The following is a description of a gene set: studied in species Mus musculus from publication Chen Y, Wang X (PMID 31504780) Mouse Gene Set: MIR_6900_3P Genes predicted to be targets of miRBase v22 microRNA mmu_miR_6900_3p in miRDB v6.0 with MirTarget v4 prediction scores > 80 (high confidence targets)., and this is the list of marker genes: Mbnl2, Cers6, Cd226, BC061237, Peg10, Ski, Fmo2, Trim45, Nefl, Akap7, Rims2, Mkks, Nkain2, Vps33a, Cx3cl1, Ap1s2, Rgs9, Smurf1, Kansl1, Mdga1, Lhx5, Zfp365, 1700066M21Rik, Rack1, Fhip1b, Stk32b, D630003M21Rik, Atg10, Rnf115, Thrb, Arhgdib, Virma, Klf11, Acsl6, Brox, Clvs1, Shisa7, Nnat, Cul2, Crtc1, Rara (retinoic acid receptor, alpha), Patl1, Prrx1, Mxd1, Cybb, Zfp810, Atxn7l1, Nbea, Loxl1, Zfp148, Ids, Cip2a, Gm5800, Fbxo22, Nxph1 (neurexophilin 1), Cyp2ab1, Cyfip1, Scn8a, Scd1, Seh1l, Gigyf2, Bcl2l11, Ramp1, Selenoi (selenoprotein I), C1qtnf6, Zbtb34, Lrrcc1, Arhgap30, Loxl3 (NCBI Gene Id 16950), Zfp971, Saraf, Spib, Slco3a1 (NCBI Gene Id 97427), Shc1, Kmt2c, Cd96, Foxd4 (NCBI Gene Id 14237)